The following is a description of a gene set: studied in species Homo sapiens We used microarrays to detail the global programme of gene expression by circulating TCRVgamma9+ gamma delta T cells isolated from healthy individuals,tested either as resting cells or cells activated by phosphoantigen BrHPP and IL-2at an early(+6hrs) and a late (+7days) timepoint. We find that with more “NK cell” genes than alphabeta T cells and more “T cell” genes than NK cells, the circulating TCRVgamma9+ gamma delta T cells cells have a hybrid transcriptome. The gene signature of the activated cells recapitulates their physiological functions: Th1 cytokine, chemokine and cytotoxic activities at first and mitotic activity at later time points. The gene expression pattern of activated normal gamma delta T cells is nevertheless clearly distinctive from that of NK/T and peripheral T cell lymphomas of the gamma delta subtype. Genes up-regulated in gamma delta T cells activated by phophoantigen BrHPP and IL2: 0h versus 6h. from publication Pont F, Familiades J, Déjean S, Fruchon S, Cendron D, Poupot M, Poupot R, L'faqihi-Olive F, Prade N, Ycart B, Fournié JJ (PMID 21968650) Human Gene Set: GSE27291_0H_VS_6H_STIM_GAMMADELTA_TCELL_UP, and this is the list of marker genes: SUGP2, IGSF9 (NCBI Gene Id 57549), PRKAR1B, C15orf40, PFKL, IL5RA, IL22, VMA21 (vacuolar ATPase assembly factor VMA21), TMEM209, ACSL4, ZMYM3, MRGPRX4, FMNL2, WRNIP1, PDCD2, SLC14A1, HAMP, ST13, COL9A2, MRPS15, PLPP3, TMEM31, CSAD, SENP3, RAB25, TRAPPC14, ERGIC3, DRICH1, ZBTB7B, CCR8, RNF212, TCEA3, UBE4B, GAPDHS, IL2, RPS8, FOXI1, CLRN3, WBP11 (WW domain binding protein 11), CCDC22, TNKS2, STAP2, PROX1, SLC4A2, ANKRD13B, FAM238C, VAX2, TP53, TYW5, TUBA3D, TMEM39B, HIGD2A, CFAP107, ADD2, SYCN, SRSF6, LINC00543 (long intergenic non-protein coding RNA 543), ARHGEF38, CLSPN, OR51M1, CYSLTR1, NSUN5P1, SDHAF3, DDX55 (NCBI Gene Id 57696), DPY19L2, TCN1, SDF4, SYTL4, EIF3I, VPS35L, AFF2, HHATL, MAGEA5P, KCNE3, DANCR, CFAP100, LRRC3, AGBL1, SUMF2, N4BP3 (NCBI Gene Id 23138), UBA2, ZNF384, TOPBP1, GLUD1, PYGO2, PABPC3 (poly(A) binding protein cytoplasmic 3), PTPRM, POTEKP, SRFBP1, TBC1D4, CDK5RAP3, ZNF404, ARGLU1, GPC4, ARHGAP5, POLR3E, CDC14B, TMEM106B, GPRASP3, TRIM16, KDM4C, DAW1, MSRA, NSUN5P2, ZNF175, TUT4, FXYD6, SREBF2, NSUN4, SEPTIN1, IL17RC, ZNF738, MASP2, LINC01579, GOLGA2P5, ZNF850, IRF2BP2, ZKSCAN1, CEP72, AHSA1, LSM12, BTK, MACROH2A2, LINC02347, SBNO2, CHTF8, FAM227B, ZNF789, MAZ, NSUN5, PRPF39, NECAB1, MCRS1, P4HTM, SNTG1, PABPC4, SETD4, NDUFS7, CHORDC1, RNF215, HLX (H2.0 like homeobox), LONRF3, RASGRP2, SRSF5, GPR108, CENPT, DEFB114, ADGRG6, ZNF485, GNAZ, STAT6 (signal transducer and activator of transcription 6), KCTD18, ZNF32, GPRC5D-AS1, SLC15A2, BOLA3, PKM, HTR5A, RPS27A, IREB2, PPA1, HSF4 (NCBI Gene Id 3299), RNASEH2A, YJU2, NSA2, CNIH1, TARS1, BECN1, ALPI, RPL11, RAB20, FZD6, SERPINB7, FASN, MPHOSPH9, LINC01512 (NCBI Gene Id 285858), AGTR1, SLC52A1 (NCBI Gene Id 55065), GPR6, ZNF275, PIH1D1, CD160, SPSB1, PIP5K1A, CA5BP1, CNOT3, RPS17P5, TMEM123, FOXR1, NFIL3, RPL36A, ZNF875, C11orf24, CDCA7, ZFP69